Given this list of marker genes GPR15LG, KANK2, MIR15B (NCBI Gene Id 406949), CRLF3, CACNB4, JADE1, GIGYF2 (NCBI Gene Id 59281), DLG1, RBL1, DGKZ, KLF4, MIR451A, MIR15A, WEE1, TP53, MIR892B, FAM107A, CCND1, RBL2, BRD7, SUSD2, FBXO31, RPA2, TMSB4X, CTDSP1, MIR638 (NCBI Gene Id 693223), ACVR1, SDE2, PLK3, TREX1, ZC3H12D, MIR503, MIR873, EZH2, E2F7, RB1, INHBA, DCUN1D3, PTEN, SLFN11, MIR137, CDKN2B, APBB1, CDKN1A, RFWD3, CDK2AP2, CCL2, MIR26A1, MIR29A, GPNMB, RPS27L, ZNF655, DACT1, BCL2, CDK2, PKD2, PRKDC, TRIAP1, CDKN2D, MIR133A1, MIR362, SOX2, GFI1B, MIR30C2, MIR10A, MIR193A, MIR16-1, FHL1, MUC1, BTN2A2, APC, CDC73, CTDSPL, CTDSP2, WAC, MIR29B1, MIR133B, TFDP3, MYO16, PRMT2, FBXO7, MIR29C, here is a description of the gene set: Human Gene Set: GOBP_NEGATIVE_REGULATION_OF_CELL_CYCLE_G1_S_PHASE_TRANSITION Any signaling pathway that decreases or inhibits the activity of a cell cycle cyclin-dependent protein kinase to modulate the switch from G1 phase to S phase of the cell cycle. species: Homo sapiens